The following is a description of a gene set: species: Homo sapiens cell line expressed genes. Human Gene Set: MODULE_118, and this is the list of marker genes: GDF15, ARHGDIB, RND3, MAGI1, EMP1, GGH, S1PR4, RNASEH2A, VSIG4, TFAP2B (NCBI Gene Id 7021), SMTN, FLNA, CASP2, TACC2 (transforming acidic coiled-coil containing protein 2), TPM2, S100A11, DDX11, M6PR, CCL3, MMP1, PLOD2 (NCBI Gene Id 5352), FZR1, ZWINT, EDA, CTSC, DLGAP5, CCNB1, TM4SF1, KNTC1, SCHIP1, GTSE1, CCNA2, ZIC2, ZBED4, RAC3, MAT1A, ATOSB, TPM1, AMELX, NTS, PLIN2, MYB, CDC25B, MCM2, DHFR, ARID1A, TIMP3, DSP, SLC22A18AS, KRT19, CHST3, CCNF, ATF5, HCK, TBX1, PAX6, PEG10, FN1, PIR, MFAP2 (NCBI Gene Id 4237), PRSS23, GPR3, ZYX, MAGEA4, PDE4B, ACTN1, EIF4EBP1, HTR4, RGS10, RGS16, PPT2, ACSL3, TOPBP1, GAS1, ELAVL2, SIT1, CD79A, RECQL4, GAGE12F, RRM2, PHLDA2, JUNB, ILF3, KCTD17, CDKN2C, PRB4, LGR5 (NCBI Gene Id 8549), CCDC9, FOS, TYR, VWF, CD151, EPB41L3, FGFR1, SPP1, ENG, ARHGEF6, IFI27, PRSS2 (NCBI Gene Id 93431), ABCA1, FCER1G, MCM3, CCNB2, KCNN4, RAD54L (RAD54 like), NNMT, ANXA1 (annexin A1), AIF1, DTYMK, TCL1A, ECE2, FST, RGS1, TMEM158, MMP2, MCRS1, MAFF, CDC45, LOXL2, NPAS1, IER3 (immediate early response 3), CALD1, CALU, CHAF1A, UCN, IGHM, SLA, GULP1, MAGEA3, TMEM106C, PKMYT1, SOX4, IGFBP4, AMBP, ITGB5 (integrin subunit beta 5), ALDH7A1, HSPG2, EPHA2, MTHFR, EXD2, CTSG, CCL2, SHBG, CD3D, ALOX5AP, PAX7 (paired box 7), KCND3, PAICS, PLAU, SEC11A, NCAPD2, GJA1, CD22, KRT18, EXOSC2, PEPD, TNFRSF10B, PTPRC, BIK, RAB31, CYP1B1, IFIT1, CDH2, ACKR1, LMNB2 (lamin B2), BUB1B, DNASE1, INSIG1, IKBKG, NQO1, PDLIM4, NHERF1, ADA, CRABP1, IGF2BP3, S100A8, ORM2, CLDN9, DOCK2, RRM1, CAV2, AQP8, DDX21, CHST15, GMPS, KIF14, E2F1, LRCH4, CCL7, PCLAF, TNF, CRIM1, LCP1, LOX, PLAT, GYG1, CDKN3, ITGA6, MMP9, CSRP2, PAFAH1B3, EZH2, PTP4A3, AP1M1, COL4A1, TOP2A, MACIR, SLC6A7, KCNQ3, PPP4R2, PRAME, TNC, RECQL5, PSMB8, CCND2, BASP1, ZMPSTE24, MYBL2, CNN3, SALL2, MNDA, IGF2, DMBT1, SERPINE1, SOX10, EMP3, PARP2, MYOZ3, CHPF, COL5A2, RIBC2, CCL15, MLLT11, H2BC12, CSE1L, IL2RG, CCHCR1, SGCE, UBE2C, CKS2 (CDC28 protein kinase regulatory subunit 2), RCC1, PCNA, EFEMP1, PDGFRA, MGLL, RBP1, APOC1, CARD10, CENPA, LAIR1, MSI1 (NCBI Gene Id 4440), CXCL1, ITGA3, LAMB1, NRG2, CNKSR1, GPSM3, ALDH1A1, KIF21B, CORO1A, FADS1, SFTPC, S100P, SRGN, MCM4, COL10A1, UNG (uracil DNA glycosylase), NUP205, DUSP6, OLFML2B, ENTPD2, CD24, CDC20, FDPS, EPCAM, UBXN1, H4C3 (NCBI Gene Id 8364), IGSF3, H2AX, MYC, SRPK1, SLC7A5, WIZ, SLC2A1, RCN2 (reticulocalbin 2), DLK1, TRPM2, BCL2A1, MLC1, CD33, MKI67, PFKFB2, CENPF, LMO2, TMSB15A, SV2A, QPCT, CD37, VPS11, SRPX, PRPF19, CAV1, SLC7A11, CDKN1A, CST7, ACR, RAI14, TMX1, TGM2, MPO, LMNB1, CAVIN1, IL7R, DBN1, SIX6, HAP1, THBS1, NUDT1, KIFC1, DDIT4, S100A4, DPYSL3, ID2B, GALR3, LAPTM5, CEP135, HLA-DQA1, BMP10, TPX2, IGFBP2, UGDH, POLD2, GRN, HMMR, ITGB2, PLK1, TROAP, PROM1 (NCBI Gene Id 9634), PRELID3A, ADAM9, CD53, GET1, CCN1, MCM6, IL1RAP, LDLR, LSP1, LRIT1, ENO2, PNP, GPC3, ISG15, STMN1, DDX3Y, GNG7, FADS2, DKK4, RPA3, GSTM1, DPH2, CCL5, CDKN2A (cyclin dependent kinase inhibitor 2A), DAPK2, SYNGR4, PSPHP1, CDK1, SLC6A11, SCAMP5, IRAG2, CXCR4, NPM3, CLEC2B, HTRA2, AGXT, ADAM19, GFPT2, SLC16A3, PER1, GNG12, ALCAM, NDC80, RAC2, TGFBR2, APOC4, NECTIN1, TMSB4Y, RRP7A, ODF1 (NCBI Gene Id 4956), PTPN7, RFC4, TRIP13, FEN1, CCL4, ABCB9, TTI1, AANAT, HPRT1, AKAP12, ATP4A, PTTG1, SCN2B, FOXM1, MYO10, KIF11, MDK, BTBD3, MAD2L1, DBP, SORD